The following is a description of a gene set: Glial cell differentiation Human Gene Set: WP_GLIAL_CELL_DIFFERENTIATION species: Homo sapiens, and this is the list of marker genes: MSN, PLP1, MBP, MAG, CNP, GAP43, MIR206 (NCBI Gene Id 406989), TPPP